Given this list of marker genes USPL1, RAB39B, MTBP, PHLPP2, FANCB, TCF4, GFAP, PON3, TPK1, TNFRSF21, LCP1, CCNG1, PLS3, RAP1A, AMBN, TUBGCP3, MIS12, CCDC50, TCP1, SRP72, ERRFI1, RBBP8, HECTD2 (HECT domain E3 ubiquitin protein ligase 2), FUS, GCNT1, COX6B2, RAD54L, ASNS, MCM5, PDZK1IP1, EDA2R, PLA2G1B, MCU, CUL2, PRSS38, POLK, GFPT1, NCAPG, SLC19A2, SCNN1G, GAB2, MYOF (NCBI Gene Id 26509), MRPL57, DBF4, CPQ, RRM1, PLK4, MDM2, UAP1, IKBKE, ISG20 (interferon stimulated exonuclease gene 20), SLC3A2 (solute carrier family 3 member 2), CPE, KCNK5, SPCS2, ECPAS, MANEAL (mannosidase endo-alpha like), SERPINI2, PKHD1L1, UBIAD1, PDCL2, CENPC, BBS12, DNAJC25, ADCY8, LGI2, TPI1, USP54, UBE2L6, MDM4, PLP2, PSIP1, MIS18BP1 (MIS18 binding protein 1), ARMCX4, KTN1, ANGPT4, CKAP5, NUDCD2, CEP192, NET1, ANLN, MRE11, CXXC4, HAUS6, SSR1, RBM15, KPNA2, CSF2, CEP76, MTREX, DPY19L4, ICA1, ORC2, GAPDH, PSMB11, MANSC1, ANKRD34B, CLSPN, SH3BGRL, TRO, UTP18, TUBGCP4, GRAMD1C, MCM4, SNX16, NUBPL, HSD3B2, FBXO4 (F-box protein 4), GMDS, HNRNPLL, TMX1, PGK1, USP1, RNASEH2B, CNTLN, CSN2, PRIM2, ZFYVE9, CGA, FAM43A, LARS1, SLC33A1, NHLRC2, FANCC, MALT1, FAM98B, PMAIP1, SEL1L, KNL1, CBX5 (NCBI Gene Id 23468), ACTR3, OSGEPL1, TSHZ1 (teashirt zinc finger homeobox 1), TAF15, SERPINC1, PPAT, SLC39A8, GAS2, BCAP29, BCAT1, BCL2L14, FAM199X, SERPINB12 (NCBI Gene Id 89777), ACE2, NF1, ABHD10, GP2, IFITM2, EXO1, TMEM62, DCTD, NDC1, CDK6, here is a description of the gene set: Analysis of expression profiles of human pDC cell line (CAL1) compared to an immature T cell line (MOLT4) species: Homo sapiens Human Gene Set: GSE12507_PDC_CELL_LINE_VS_IMMATUE_T_CELL_LINE_UP from publication Cisse B, Caton ML, Lehner M, Maeda T, Scheu S, Locksley R, Holmberg D, Zweier C, den Hollander NS, Kant SG, Holter W, Rauch A, Zhuang Y, Reizis B (PMID 18854153) Genes up-regulated in CAL1 cells (plasmacytoid dendritic cells) versus MOLT4 (immature T cells).